Given this list of marker genes APH1B, SQSTM1, PSENEN, UBC, APH1A, PSEN2, ITGB3BP, NCSTN, TRAF6, PSEN1, MAPK8, UBB, NGF, RPS27A, NGFR, UBA52, here is a description of the gene set: species: Homo sapiens Human Gene Set: REACTOME_NRIF_SIGNALS_CELL_DEATH_FROM_THE_NUCLEUS NRIF signals cell death from the nucleus